The following is a description of a gene set: species: Homo sapiens part of: Diseases of signal transduction by growth factor receptors and second messengers Reactome Pathway: Signaling by PDGFR in disease PDGFRA and PDGFRB are type III receptor tyrosine kinases that promote development and maintenance of mesenchymal tissues, including vascular smooth muscle, kidney, intestine, skin and lung, among others. Signaling through PDGF receptors stimulates cell proliferation and survival through activation of downstream signaling pathways including the RAS-MAP kinase cascade, PI3K signaling and STAT signaling. Aberrant signaling through PDGF receptors is implicated in a number of human diseases. Point mutations in PDGFRA and, to a lesser extent, PDGFRB are implicated in a number of cancers, such as gastrointestinal stromal tumors (GIST; 5-10% mutation frequency in PDGFRA) and haematological cancers. In addition, amplified signaling through the PDGF pathway can arise through gene fusion events or overexpression of ligand or receptor through gene amplification., and this is the list of marker genes: SOS1, GRB2, HRAS, PIK3R1 (phosphoinositide-3-kinase regulatory subunit 1), KANK1, KDR, KRAS, ETV6, WDR48, PIK3CB, STAT3, PDGFRA, PIK3CA, PIK3R2, STAT1, FIP1L1, BIN2, NRAS, GOLGA4, STRN